Given this list of marker genes Mier1, Gfi1, Myc, Cry2, Sin3a, Gata1, Zfpm1 (zinc finger protein, multitype 1), H1f0, Foxo3, Elane, Hdac4, Drap1, Phf12 (NCBI Gene Id 76807), Bin1, C1d, Gli3, Arid4a, Insm2, Gmnn, Bhlhe41, Jazf1, Prdm16, Sp1, Jun, Tbl1x, Mxd1, Lin9, Runx1t1, Rcor1, Pou5f1, Ccnd1, Mdm4 (NCBI Gene Id 98570), Ski, Trp53, Ctbp1, Ncor2, Cbx5, Tbl1xr1, Max, Insm1, Dr1, Etv3, Jund, Lin52, Coro2a (NCBI Gene Id 320131), Prdm10, Ctnnb1, Akirin2, Sdr16c5, Lin37, Lin54, Pasd1, Rbpj, Zbtb16, N4bp2l2, Hoxc9, Relb, Hdac2, Sp3, Hey2, Rest, Gps2, Bmyc, Hdac1, Cdx2 (caudal type homeobox 2), Ddx20, Hmgb1, Tbx18, Tbx15, Ctbp2, Hdac3, Hdac5, Depdc1a, Hdgf, Men1, Ctnnbip1, Rbbp8, Mdm2, Spen, Ncor1, Per2, Ywhab, here is a description of the gene set: studied in species Mus musculus A protein complex that possesses activity that prevents or downregulates transcription. Mouse Gene Set: GOCC_TRANSCRIPTION_REPRESSOR_COMPLEX